Given this list of marker genes POU3F4, SYNCRIP, BCL6, SP1, LYPD4, GAB2, RUNX1T1, PLAG1, LMO3, RTKN, C1orf87, EHD4, HOXC4, VN1R3, NEUROD1, MITF, JAKMIP2, ANP32E, LCOR, VGF, MAF, EBF1, OLFML1, CDC25C, PAX6, RGS12, FBXL19-AS1, COQ8B, TNKS1BP1, MARS1, ATP5MC2 (ATP synthase membrane subunit c locus 2), MAB21L1, SALL3, CDH10, NCAM2, LMOD3, HOXB6, EBF2, PTK7 (NCBI Gene Id 5754), EMP3, PTH2R, MTUS1, LSAMP, STMN1 (stathmin 1), CRYGS, SIAH3, SLC4A10, YBX2, KCNA2, LENG9, PIAS3, ATP1B1, SOX5, HOXC5, SLC10A7, KHDRBS1, CTNNA3, ATAD3C, CCP110, SLC24A4, MBD6, KCNJ3, PDZK1, ZBTB20, RALY, EPHA1, ELAVL4 (NCBI Gene Id 1996), CIITA, NUDT13, OGG1, STAT3, HDAC9, DPYSL3, FOXP2, TMEM192, TRMT112, ARHGAP9, NPPC, NHLH2, TRIML2, ACIN1, P2RX7, CHN2, TCTA, MYF5, ALDH1A2, CEP120, SRCAP, STXBP6, LRRC19, PUM1, LMO4, TGFB3, TMEM184A, PRDX5, RASGRF1, LHX1, EFNA1, NHLRC1, ORMDL2, ZNF547, PATL1, CCDC91, MEIS2, LINC03124, NCDN, FGFBP3, RSKR, TMEM86A, PCSK1N, COL3A1, RNF19B, MRPL49, DIO2, MDGA1, C14orf119, CHCHD7, FSTL3, G2E3, TMEM255A, JARID2, ABTB2, ZC3H11A, KLF14, PRKAG1 (protein kinase AMP-activated non-catalytic subunit gamma 1), PRR35, C12orf50, PABPC1, VSNL1, DLX1, NCAM1, TAFA1 (NCBI Gene Id 494552), SEMA3A, PPARGC1A, CASQ2, CARMIL3, DLX5, NPHP3 (nephrocystin 3), CSRNP2, MACROD1, RARB, DMD, CNTN2, LMTK2, SYMPK, RTN4, PCDH9, ITPKC, HOXA3, NR2F1, ABHD4, ARHGEF11, GJD2, PI15, CDKN2C, BRINP3, SREK1, TLE4, GRM3, GSK3A, PITX2, CREB5, HSD11B1, FABP7, COLCA1, IRF2, KLHL2, ACMSD, CDKL5, PRMT6, ATP5PD, MAP2K6, LRP2, PITX1, MEF2C, CLDN2, SLITRK1, BFSP2, UQCRH, GFRA3, MN1, LUC7L3, ATOH7, RHOA, SGTB, NLN, PRRC2C, SLC4A2, TGM7, CHODL, B3GLCT (NCBI Gene Id 145173), AMD1, FXYD3, ASTN1, ZBTB41, STRIP1, NFATC4, GEN1, TCF12, DMRTC2, CNIH2, CELF4, ARHGDIB, LRP1, FOXG1, MRFAP1, PCDH17, SNAP25, DDIT3 (DNA damage inducible transcript 3), SDF2, LRRC41, SARNP, LBX1, OPHN1, CDKN1B (cyclin dependent kinase inhibitor 1B), HNRNPA0, SUPT6H, LRP5, RALYL, FAU, MADD, NPTX2, GPR65, FOXA3, BNC2, PSMD11, IP6K2, FSTL1, KICS2, SSH2, P2RY10, CRIM1, DCHS2, SLF2, HOXA7, HMCN1, CTCF, DNASE2B, HNF4G, NEUROG1, NRG2 (NCBI Gene Id 9542), TBX20, MTSS1, MEOX2 (NCBI Gene Id 4223), ASIC1, DCAF6 (NCBI Gene Id 55827), CEP41 (centrosomal protein 41), ISL1, here is a description of the gene set: studied in species Homo sapiens Genes having at least one occurrence of the motif ARATKGAST in the regions spanning 4 kb centered on their transcription starting sites. This matches the FOXM1 transcription factor binding site V$FOXM1_01 (v7.4 TRANSFAC). Human Gene Set: FOXM1_01